Given this list of marker genes RTEL1, GJA1, FIG4, GJB3, TAT, LAMA3, AQP5, GJB4, FERMT1, RHBDF2, KRT2, KDSR, CTSC (cathepsin C), FGFR2, SASH1, SLCO2A1, JUP, MCOLN1, CSTA, LAMB3, MTX2, BRAF, KRT74, SDR9C7, KRT6B, USF3, SDHD, MBTPS2, LORICRIN, ALOX12B, KRT14 (NCBI Gene Id 387571), PIGL (NCBI Gene Id 9487), KLK11, KLLN, SEC23B, NHP2, KRT1, MMP1, DST, DSP, STS, PLEC, KRT85, ENPP1, TERC, SNAP29, GRHL2, TINF2, GJB2, SERPINB7, KRT6A (keratin 6A), KRT10, PARN, LAMC2, KRT9, SDHC, CST6, SRD5A3, AAAS, TNFRSF1B, AAGAB, NECTIN1, LSS, KRT83, TUFT1, CARD14, NLRP1, KRT16, POMP, DKC1, TRPV3, CD28, PKP1, KANK2, DSC2, SDHB, TP63 (tumor protein p63), KRT17, VPS33B, NPM1, WNT10A, CTLA4, KRAS, COG6, COL14A1, SMARCAD1, PPP1R13L, KRT6C, GJB6, CFTR, CTC1, MAP2K1, MAP2K2, NIPAL4, PIK3CA, TERT, USB1, CAST, NOP10, SULT2B1, CERS3, KLHL24, TGM1, ALOXE3, RSPO1, AKT1, AP1B1, CYP4F22, SLURP1, COL7A1, ABCA12, PEPD, WRAP53, PDGFRB, PTEN, GMPPA (GDP-mannose pyrophosphorylase A), PNPLA1 (NCBI Gene Id 285848), KRT5, TRPM4, DSG1, PERP, TRAPPC11, ATP2A2, HPGD, COL17A1, TYMS (NCBI Gene Id 7298), SERPINA12, ITGB4, here is a description of the gene set: Human Gene Set: HP_PALMOPLANTAR_HYPERKERATOSIS species: Homo sapiens Palmoplantar hyperkeratosis Abnormal thickening of the skin localized to the palm of the hand and the sole of the foot.